The following is a description of a gene set: species: Homo sapiens Oxidative stress genes down-regulated in ARPE-19 cells (retinal pigmented epithelium) in response to HNE and tBH. Oxidative stress plays a key role in aging diseases of the posterior pole of the eye such as age-related macular degeneration. The oxidative stress response of in vitro RPE cells has been studied for a small number of genes. However, a comprehensive transcriptional response has yet to be elucidated. The purpose of this study was to determine if the transcription of a common set of genes is altered by exposure of ARPE-19 cells to three major generators of oxidative stress, hydrogen peroxide (H2O2), 4-hydroxynonenal (HNE), and tert-butylhydroperoxide (tBH). As expected, a common response was observed that included genes differentially regulated by all three treatments. Of these, only one gene was upregulated, and only by one oxidant, while all other responses were downregulation. The majority of these genes fell into five functional categories: apoptosis, cell cycle regulation, cell-cell communication, signal transduction, and transcriptional regulation. Additionally, a large number of genes were differentially regulated by one oxidant only, including the majority of the conventional oxidative stress response genes present on the Clontech Human 1.2 microarray. This study raises questions regarding the generality of results that involve the use of a single oxidant and a single cell culture condition. from publication Weigel AL, Handa JT, Hjelmeland LM (PMID 12419474) Human Gene Set: WEIGEL_OXIDATIVE_STRESS_BY_HNE_AND_TBH, and this is the list of marker genes: ATR, BRAF, SELENBP1, CTSL, CAPN2 (calpain 2), ITGA6, NFATC1, GPX2, ERBB4, YWHAH, CLU, MARK3, CDKN1C, FASTK, BCL2L1, NME2, MYLK, IL6ST, CPE, HBEGF, CD47, ETS1, TADA3, PPP1CA, EFNA4, IGF1R, SMAD1, PPP3CA, MLH1, TERF1, RARB, IL9, DFFB, DST, RXRB, E2F1, ERCC5, STAT6, ETV3, LYN, ETS2 (ETS proto-oncogene 2, transcription factor), HSPA2, CREB1, IL3, TNFRSF1A, GAK (NCBI Gene Id 2580), BMP1, SP2, BAD, YBX3, TSG101, ITSN1, TCF3, REL, HTT, CTTN, TSPAN31, S100A1, EZR